The following is a description of a gene set: Reactome Pathway: Vitamin E transport This event has been computationally inferred from an event that has been demonstrated in another species.<p>The inference is based on the homology mapping from PANTHER. Briefly, reactions for which all involved PhysicalEntities (in input, output and catalyst) have a mapped orthologue/paralogue (for complexes at least 75% of components must have a mapping) are inferred to the other species. part of: Metabolism of fat-soluble vitamins species: Mus musculus electronically inferred by orthology from the curated human pathway, and this is the list of marker genes: Ttpa